The following is a description of a gene set: from publication Yevshin I, Sharipov R, Kolmykov S, Kondrakhin Y, Kolpakov F (PMID 30445619) Mouse Gene Set: TRPS1_TARGET_GENES studied in species Mus musculus Genes containing one or more binding sites for (Trps1) in their promoter regions (TSS -1000,+100 bp) as identified by GTRD version 20.06 ChIP-seq harmonization., and this is the list of marker genes: Ccl27a, Sde2, Manba, Tln1, Bst1, Igsf9, Afdn, Psd4, Vps25, Nppb, Mir203, mt-Tp, Pik3r2, Ormdl3, Firrm (NCBI Gene Id 381306), Uba7, Oaz1, Comt, Gm38158, Stx4a, Syde1, Has2os, Ubl4a, Frmd4b, B230216N24Rik, Por (NCBI Gene Id 18984), Duoxa1, Gm17977, Cwc27, Klk9, Slc52a2, Creb5, Cald1, 2410006H16Rik, Stra6, Tmprss4, Clcn3, Aebp2, Ccn2, Nenf, Pcgf1, Tjp2, Stam (NCBI Gene Id 20844), Ube2z, Smim11, Mir7648 (microRNA 7648), Alg10b, N4bp3, Atg4d, Pkia, Sh3bgrl2 (SH3 domain binding glutamic acid-rich protein like 2), Tmprss11f, 1700012I11Rik, Myo18a, Mon1b, Hmbox1, Dnajb6, Tnfrsf26, Hyal2, Osbpl2, Trim6, 9130604C24Rik, Ndufa9, Pip4p2, Crlf3, Gstm1, Card6, Pam, Sirt6, Kmt5a, Eif1ad14, Creg1, Pxylp1, Gm5034, Ciao3, D630024D03Rik, Mrgpre, Msh5, Polr2j, Trim16, Dtd1, Ints9, Septin9, Gpatch1, P2ry12, Rffl, Ints2, Cdca2, Cpox, Duxf1, Kpna2, Aig1, Mynn, Tm4sf1, Spry1, Syt8, Eps8, Gm9929, Gm12607, Csf2, Lect2, Lrp1, Dab2ip, Tob2, Snord118, Rptor, Gmpr, 4933405O20Rik, Smarca2, Gm11550, Dhx8, Gpn3, 1700054O19Rik, Dip2b, Ankrd1, Mettl18, Npc2, Myzap, Ppia, Sigmar1, Gstcd, Cldn4, Airn, Vmp1, Cpsf1, Spata31e2, Zkscan6, Srpk1, Cuedc1, Fam136a, Apbb2, Vkorc1, Nsd3, Unc13d (unc-13 homolog D), Gm17059, Slc26a11 (solute carrier family 26, member 11), Stat6, Ppp1r2, Tmcc3, Dsp, Wincr1, Arid1a, Fpgs, Styk1, B930094E09Rik, Dhrs1, 1700008J07Rik, Gm25582, Trps1, Focad, Aloxe3, Ly6e, Lmo7, Gm20620 (NCBI Gene Id 108167695), Zfp414, Gm26535, Polr2e, Zfp609, Dynap, Arl6ip5, Gm15564, Rpl41, Rbbp8, Psmb6 (NCBI Gene Id 19175), Tmem132c, Ikbke, 2810408A11Rik (RIKEN cDNA 2810408A11 gene), Ints12, Isca2, Zwint, Crip1 (cysteine-rich protein 1, NCBI Gene Id 12925), Tfam, Lsp1, Krt80, Sertad2, Zfp672, Scd4, Plp2 (proteolipid protein 2), Olfm2, Ampd3, Rnu11, Spty2d1, Gm12094, Scaf11, Tspan4, Fgfr2, Klra1, Fermt2, Ptpn5, Gm12495, Nt5c3b, Dpm1, Ndel1, Kxd1, Gm13481, Abca8b, St3gal4, Lasp1, Gm26651, Smad5, Srsf1, 9330111N05Rik, Dhrs7, Ankrd35, Sh3bp5, Zc3hc1, Dcp1a, Casq2, Tars1, Syt12, Cdc42bpb, Sema4b, St3gal2, Septin11, Ttc39aos1, Dennd6b, Vstm5, Maea, Got1, Ccna2, Pafah2, Bnip3l, Nmnat2, Srcap, Nprl3, Snord49b, A930007I19Rik, Gpld1, Flii, Tsc22d1, Tmem63a, Ctu2, Hps1, Ints10, Mir3967, Arhgap23, Zbtb24, Rpl4, Amotl1, Muc1, Gm15889, Ccdc96, Polh, Bptf, Slc25a35, Fbxo11, Rny1, Adgra1, Zfp426, Aqp3, Coro2a, Plxnb2, Pdrg1, Tex30, Mocs3, Slc45a4, A430093F15Rik, Pop7, Rpia, Upp1, Gdf9, Zfp365, Crk (NCBI Gene Id 12928), Snhg16, Dab2, Zfp524, Pabpc4, Ticam1, Commd5, Ankrd22, Serpinb2, Pmm1, Gm4610, Gm16253, 3110070M22Rik, Fam83a, Bin1, A930024E05Rik, Pacsin2, 1700030C14Rik, Hdac7, Serpina3h, Gm36535, Etl4, Dok2, Atg9b, Tigit, Dynlt2b, Stimate (STIM activating enhancer), Gm11714, Sprr1a, Myc, Calhm5, Gm12976, Rnf224, Pfkm, Tcf3 (NCBI Gene Id 21423), Mrps15, 4930581F22Rik, Snord49a, Usp46 (NCBI Gene Id 69727), Oasl1, Helq, Rad1, Med6, Mir1907, Sfr1, Ighv1-69, Ivl, Gm8041, Hsd11b1, Fam110b, Rcn1, 2610307P16Rik, Taco1, Dph1, I830134H01Rik, Gm8357, Ywhag, Cish, Eef2k, Dnaja3, Tada2a, Ogfod3, Gm13536, Gm15337, Rbbp8nl, Yipf2, Ccdc117, Uqcrq (ubiquinol-cytochrome c reductase, complex III subunit VII), Egfl7, Rreb1, Ttc33, AI429214, Osbpl3, AU015336, Scmh1, Csgalnact2, Derl1, Itpr3, Mir181a-2, Galnt10, Tcte2, Ctcf (CCCTC-binding factor), Sh3tc1 (SH3 domain and tetratricopeptide repeats 1), D130052B06Rik, Bpifb4, Clcn7, Phxr4, Ccdc107, Ric1, Lrig1 (NCBI Gene Id 232256), Pou2f3, Bace1, Zpld1, Gm10222, Fiz1, Tmem132a, Runx2os2, Map7d1, Ap5s1, Cln8, Gm12508, Bud13, Tmem71, Prdm4, Nipal2, Rab3gap2, Prss52, Gm13003, Hnrnpr, Gm13877, Pold2 (NCBI Gene Id 18972), Gm5475, Mef2c, Gm5530, Aldh3b1, Tmpo, Mfsd13a (NCBI Gene Id 75146), Lmbrd1, Gm22322, Ralgapb, Ppp1r8, BC006965, Gm35066, Zwilch, Gemin5, Il22ra1, Lrrn4cl, Zfp809, Zfp62, Klf3, Gm19391, Tmem54, Sox9, Lrtm2, Rab25, Gm15938, Mef2d (myocyte enhancer factor 2D), Klk10, Hsp90aa1, Padi2, Zfp280b, Srek1ip1, Ap1m1, Rrm2, Crip2, Psmb10, Mir6236, Slc25a21, Gm15473, Smad3 (SMAD family member 3), Phldb2, Fbxw5, Oit3, E230013L22Rik, Krt16, Smpdl3b, Sh2d3c, Man1b1 (NCBI Gene Id 277406), Isg20, Epb41l1, Shroom3 (NCBI Gene Id 52200), Arhgef1, Spag9, Gm29340, Parl, Dennd11, Coq8b, Marchf10, Pgk1, Gm7626, Gm17057, Parva, Eif2b2, Fam216a, Gm12092, Krtap5-4, Nt5dc3, Galt, Cox7a1, Slc16a13, Sema3b, Slc10a3, Defb14, Gm11400, Ifi27l2b, Map3k2, Krtap4-16, Ints1, Atp6v1f, Lactb2, Gga1, Sh3gl1, Rad50, Selenom, Ttc39a, Wdtc1, H4c6, Txnrd2, 2610005L07Rik, Sec24a, Arrdc1, Mrps12, Snx10, Lims1, Il6ra, Ptp4a2, Rnf11, Ccdc57, Gm29346, Mark2, Mbnl1 (muscleblind like splicing regulator 1), Ogt, Opn1sw, Aldh9a1, Tns3, Cuedc2, Padi6, Rab15, Gfpt1, Polg2, Phykpl, Mad1l1, Hes1, Smim3, mt-Tl1 (mitochondrially encoded tRNA leucine 1), Mgst2, Brix1, Cenpv, Bin2, Gm12295 (NCBI Gene Id 327946), Gsto2, Traj32, Ablim1, Slc35b1, Gm20716, Smurf1, Rnf166, Foxn1, Micall1, Gm12216, Col7a1, Xpo5, Lce1g, Pole, Atf6, C3ar1, C1qtnf1, Tob1, Havcr2, C130073F10Rik, Gm15722, 2310022A10Rik, Snord1c, Vim, Pmp22, Gm9917, Gcnt2, Rnf39 (NCBI Gene Id 386465), Scrn2, Furin, 5430435K18Rik, mt-Nd1 (mitochondrially encoded NADH dehydrogenase 1), Krt8, Plec, Perp, Htra1, Gramd2a, Gm14280, Kdm2b, Dlx4, Tmem134, Mir139, Hhla1, Trdv4, Mus81, Abcb8, Atf3, Rab11a, Pigx, Nanos2, Sfi1 (Sfi1 homolog, spindle assembly associated (yeast)), Mrpl33, Glipr1, Msantd2, Psmf1, Rtn4, Gm37435, Mcpt8, Slpi, Tex48, Capg, Neurl4, Mrps18c, Mir155hg, Cr1l, Tbc1d14, Slc12a5